Given this list of marker genes Tfap2a, Cftr, Wnt6, Enam, Odaph, Dspp, Slc4a2, Amtn, here is a description of the gene set: Any process that activates or increases the frequency, rate or extent of tooth mineralization, the deposition of calcium salts in tooth structures. Mouse Gene Set: GOBP_POSITIVE_REGULATION_OF_TOOTH_MINERALIZATION studied in species Mus musculus